Given this list of marker genes EGR2, MBP, DRP2, UTRN, HDAC2, NAB2, CYP51A1, SOX10, HMGCR, POU3F2, WWTR1, LAMA2, GJB1 (NCBI Gene Id 95372), SCD5 (stearoyl-CoA desaturase 5), PRX, MPZ, MAG, POU3F1, DAG1, YAP1 (NCBI Gene Id 10413), LAMB1, LAMC1, SREBF2, SMARCA4, NAB1, ADGRV1, PMP22, ADGRG6, TEAD1, here is a description of the gene set: studied in species Homo sapiens part of: Nervous system development Schwann cells are glial cells of the peripheral nervous system that ensheath the peripheral nerves within a compacted lipid-rich myelin structure that is required for optimal transduction of nerve signals in motor and sensory nerves. Schwann cells develop from the neural crest in a differentiation process driven by factors derived from the Schwann cell itself, from the adjacent neuron or from the extracellular matrix. Upon peripheral nerve injury, mature Schwann cells can form repair cells that allow peripheral nerve regeneration through myelin phagocytosis and remyelination of the peripheral nerve. This process in some ways recapitulates the maturation of immature Schwann cells during development. Mature, fully myelinated Schwann cells exhibit longitudinal and radial polarization. The axon-distal abaxonal membrane interacts with elements of the basal lamina through integrins and lamins and in this way resembles the basolateral domain of polarized epithelial cells. In contrast, the axon-proximal adaxonal membrane resembles the apical domain of an epithelial cell, and is enriched with adhesion molecules and receptors that mediate interaction with ligands from the axon.<br>Schwann cells express a number of Schwann-cell specific proteins, including components of the myelin sheath such as myelin basic protein (MBP) and myelin protein zero (MPZ). In addition, Schwann cells have high lipid content relative to other membranes, and are enriched in galactosphingolipids, cholesterol and saturated long chain fatty acids. This protein and lipid profile is driven by a Schwann cell myelination transcriptional program controlled by master regulators SOX10, POU3F1 and EGR2, among others. Reactome Pathway: EGR2 and SOX10-mediated initiation of Schwann cell myelination